Given this list of marker genes FUNDC2, SIRT1, XBP1, LDAH, FITM2, DGAT2, PNPLA2, NR1H4, SLC25A27, C1QTNF3, here is a description of the gene set: A homeostatic process involved in the maintenance of a steady state level of triglyceride within a cell. species: Homo sapiens Human Gene Set: GOBP_INTRACELLULAR_TRIGLYCERIDE_HOMEOSTASIS